Given this list of marker genes CHPF2, B3GAT2, CHST11, HYAL1, CHST3, CSGALNACT1, IGF1, DSEL, CHSY3, HEXB, B3GALT6, CYTL1, HYAL4, CHST12, XYLT1, CHSY1, CHST13, GUSB, CHST7, B3GAT1, DSE, B3GAT3 (NCBI Gene Id 26229), CSGALNACT2, CHPF, XYLT2, UGDH, SLC35B2, PXYLP1, here is a description of the gene set: studied in species Homo sapiens Human Gene Set: GOBP_CHONDROITIN_SULFATE_PROTEOGLYCAN_METABOLIC_PROCESS The chemical reactions and pathways involving chondroitin sulfate proteoglycans, which consist of a core protein linked to a chondroitin sulfate glycosaminoglycan. The chondroitin sulfate chain is composed of the repeating disaccharide unit beta-(1,4)-D-glucuronic acid-beta-(1,3)-N-acetyl-D-galactosamine, the latter of which can be O-sulfated.